Given this list of marker genes TUBB8, CTNNB1, CDC42, TUBB2A, ARPC5, TLR5, TUBB3, CTTN, FYN, YWHAZ, ARPC5L, NCK1, TUBB, TUBB1, ARHGEF2, ITGB1, TUBB2B, WASL, EZR, NCL (nucleolin), TUBB4A, TUBB6, TUBB4B, ACTG1, ABL1, TUBA1A, KRT18, OCLN, ROCK1, TUBA3C, YWHAQ, LY96, NCK2, TUBA1C, TLR4, CLDN1, ROCK2, WAS, TUBA8, ARPC2, ARPC4, TUBA1B, TUBA3D, RHOA, TUBA3E, CDH1, ARPC3, PRKCA, ACTB, ARPC1A, TUBAL3, HCLS1, CD14, TUBA4A, ARPC1B, here is a description of the gene set: Pathogenic Escherichia coli infection Human Gene Set: WP_PATHOGENIC_ESCHERICHIA_COLI_INFECTION species: Homo sapiens